Given this list of marker genes MYC, MIR1-1, GTF3C5, HMG20B, DDX17, EPHB1, SOX8, MYOD1, LARGE1, SCX, KLF5, SIX4, HLF, PAX5, SOX11, SIX1, MYOG, FOXN2, AKIRIN1, KAT8 (lysine acetyltransferase 8), EMD, VAX1, BMAL1, MEGF10, ATF3, KLHL40 (NCBI Gene Id 131377), B4GALNT2, PHOX2B, BTG2, SAP30, NUPR1, RBM24, SMYD1, EGR2, ASB2, MEF2C, GPC1, HIVEP3, BARX2, CITED2, NR1D2, MYOCD, ANKRD33, MYF5, BCL9L, LEMD2, ANKRD1, FKTN, MYF6, EGR1, SELENON, PPIF, DDX5, MED20, EEF2, EOMES, FKRP, KLHL41, TBX1, ZNF689, MAFF, WNT3A, NR4A1, MYLK2, FOS, PAX7, COPS2, MSTN, NLN, NOTCH1 (notch receptor 1), S100B, CDON, CYP26B1, KRAS, BCL9, SHH, DMRTA2, MCUB, COL6A1, UQCC2, RB1 (RB transcriptional corepressor 1), HEYL, SIRT2 (NCBI Gene Id 22933), here is a description of the gene set: species: Homo sapiens Human Gene Set: GOBP_SKELETAL_MUSCLE_CELL_DIFFERENTIATION The process in which a relatively unspecialized cell acquires specialized features of a skeletal muscle cell, a somatic cell located in skeletal muscle.